The following is a description of a gene set: Neighborhood of ATM ataxia telangiectasia mutated (includes complementation groups A, C and D) in the GCM expression compendium Human Gene Set: GCM_ATM studied in species Homo sapiens Neighborhood of ATM, and this is the list of marker genes: DRG2, AANAT, AQP2, PLK1, MPP2, PMS2P11, SCNN1G, ATM, TH, GPER1, WAS, ADRB3, HSD17B3, MICB (MHC class I polypeptide-related sequence B), RENBP, CDK13, SIRPB1, MYBPC2, KRT35, RABGGTA, NEFL, LTK, HTT, BCAT2, NR1H2, BCL3, HSF4